The following is a description of a gene set: species: Mus musculus Adipocyte abundant genes up-regulated in 3T3-L1 cells (fibroblasts induced to differentiate to adipocytes) in response to TNF. Human Gene Set: RUAN_RESPONSE_TO_TNF_UP from publication Ruan H, Pownall HJ, Lodish HF (PMID 12732648) Troglitazone (TGZ), a member of the thiazolidinedione class of anti-diabetic compounds and a peroxisome proliferator activator receptor-gamma (PPAR-gamma) agonist, restores systemic insulin sensitivity and improves the full insulin resistance syndrome in vivo. The mechanisms underlying its in vivo function are not understood. Here we investigated the potential functional interaction between PPAR-gamma and NF-kappaB in adipocytes. We show that TGZ selectively blocked tumor necrosis factor-alpha-induced and NF-kappaB-dependent repression of multiple adipocyte-specific genes and induction of growth phase and other genes. This occurs without interfering with NF-kappaB expression, activation, nuclear translocation, or DNA binding and without suppressing NF-kappaB-dependent survival signals. Notably, the expressions of some tumor necrosis factor-alpha-induced genes in adipocytes were unaffected by PPAR-gamma activation. In reporter gene assays in HeLa cells, ectopic expression of PPAR-gamma abolished induction of a NF-kappaB-responsive reporter gene by the p65 subunit (RelA) of NF-kappaB, and the inhibition was further enhanced in the presence of TGZ. Conversely, overexpression of p65 inhibited induction of a PPAR-gamma-responsive reporter gene by activated PPAR-gamma in a dose-dependent manner. The inhibitory effect was independent of the presence of NF-kappaB-binding sites in the promoter region. Other NF-kappaB family members, p50 and c-Rel as well as the S276A mutant of p65, blocked PPAR-gamma-mediated gene transcription less effectively. Thus, p65 antagonizes the transcriptional regulatory activity of PPAR-gamma in adipocytes, and PPAR-gamma activation can at least partially override the inhibitory effects of p65 on the expression of key adipocyte genes. Our data suggest that inhibition of NF-kappaB activity is a mechanism by which PPAR-gamma agonists improve insulin sensitivity in vivo and that adipocyte NF-kappaB is a potential therapeutic target for obesity-linked type 2 diabetes., and this is the list of marker genes: IFNGR1 (NCBI Gene Id 3459), HLA-B, STAT1, OR2H2, HP, ABCA1, THRSP, DCN, CP, TAP2, GBP2 (NCBI Gene Id 2634), SERPINA3